Given this list of marker genes Piezo1, Bdnf, Acvr1, Dock2, Arid1a, Hacd1, Pdlim2, Sort1, Lrp2, Scgb3a1, Shh, Mir669a-8, Speg, Akap6, Ryr1, Ift20 (NCBI Gene Id 68335), Dysf (dysferlin), Smad3, Lrrc8a, Zbtb42, Popdc2, Fzd1, Slc9a1, Mfn2, Smarcb1, Gsc, Pdcd4, Scn8a, Dock1, Pdgfra, Rgs4, Id3, Pbrm1, Abcc9, Hdac2, Pitx2, Med20, Norad, Ptcd2, Gmppa, Ccl9, Myh9, Mef2a, Eid2b, Pitx1, Notch2, Cmtm5, Sostdc1, Tsc1, Cflar, Agt, Btg2, Cryab, Mapk12, Dmd, Tbx3, Chd7, Cd164, Tgfbr3, Hlx, Pdlim7, Boc, Igf2, Lemd2, Zfp418, Hdac4, Foxl2, Adgrb1, Camk1, Hira, Col11a1, Mir669a-1, Tarbp2, Ddx5, Bnip2, Trip10, Mylk3, Alx4, Hspb2, Il6, Trim63, Krt8, Cd81, Cav1, Pdlim3, Gpc1, Mettl21c, Mir145a, Tnnt2, Phf10, Adra1b, Fhod3, Adarb1, Smad6, Btbd1, Ezh2, Disp1, Dkk1, Wfikkn1, Nek5, Sirt2, Lef1, Met, Cenpf, Heyl, Actn2, Smarce1, Sema4c, Fgf10, Bmp10, Smarca2, Ephb1, Kmt5b, Scn11a, Lama2, Rbm38, G6pdx, Ehd1, Adamts5, Skil, Ark2c, Chat, AW551984, Ddx17, Cdon, Ybx3 (Y box protein 3), Akirin2 (NCBI Gene Id 67185), Pin1, Spg11, Pdlim1, Csrp3, Bin3, Nox4, Yy1, Hamp, Snw1, Mbnl1, Plekho1, Xirp2, Sgcd, Plpp7, Klk1b1, Hes1, Adm, Gsk3b, Mapk14, Sod2, Igf1, Csrp2, Vangl2, Mir675, Cacna2d2, Med1, Dmrta2, Slc8a1, Mcub, Cth, Asnsd1, Myc, Mylpf, Fgfrl1, Rxra, Nln, Nfatc2, Ccm2l, Ehd2, Notch1, Mrtfb, Sdc1, Cfd, Fzd2, Zfpm1, Ryr2, Pax3, Wnt7b, Mymk, Fgf9, Ramp2, Ereg, Pi16, Afg3l2, Pdgfrb, Lama5, Tmtc3, Mir669a-5, Mybpc3, Plg, Prok2, Dmpk, Srf, Mir669a-7, Cacybp, Myh11, Plagl1, Fkrp, Smarca4, Mnx1, Cav3 (NCBI Gene Id 12391), Smtnl1, Svil, Actl6b, Six1, Ntn3, Fktn, Prickle1 (NCBI Gene Id 68784), Cdk9, Nr4a1, Neurl2 (NCBI Gene Id 415115), Prkg1, Lama1, Megf10, Adrb1, Flt3l, Adamts15 (ADAM metallopeptidase with thrombospondin type 1 motif 15), Casq1, Alpk3, Pin1rt1, Hdac7, Hoxd9, Myo18b, Epas1, Ldb3 (NCBI Gene Id 432840), Gpx1, Mkx, Zfhx3, Foxk1, Vegfa, Fgf3, Rtl1, Sox9, Ero1a, Chuk, Fgfr2, Cxadr, Lamb2, Cav2, Dsp, Asb2, Cfh, Prkar1a, Comp, Tmod2, Bmp4, Sox11, Maml1, Ripor2, Smad4, Cited2, Fkbp1a, Xbp1, Tgfbr1, Nfatc4, Ppard, Mir214, Mymx, Dll4, Tgfb2, Klhl40, Hey1, Asf1a, Foxc1, Or10j5, Col19a1, Nkx2-5, Uqcc2, Plekhm3 (pleckstrin homology domain containing, family M, member 3), Neurog1, Wnt5b, Rbm10, Myl9, Popdc3, Nr2f2, Ctnnb1, Kdm6b, Cntfr, Kat2a, Dag1, Cntf, Mmp14, Ang2, Myom2, Hdac9, Plec, Ybx1, Ednrb, Ctdp1, Synb, Mir669a-6, Cdk1, Tmem182, Ddx39b, Cops2, Pkp2, Ep300, Wnt3a, Paxbp1, Camk2d (NCBI Gene Id 77170), Actn4, Smarcd2, Ranbp3l, Mtm1, Heg1, Dock5, Adra1a, Mstn, Bmal1, Npnt, Fhl1, Cd9, Med28 (NCBI Gene Id 66999), Actn3, Erbb3, Mbnl3, Epor, Gpcpd1, Lmod1, Myl3, Acta1, Tmem204, Naglu, Srpk3, Cxcl10, Dicer1, Ccn4, Rara, Myl6b, Actn1, Rxrb, Klhl41, Mir669a-3, Vrk3, Pias1, Mir489, Bhlhe41, Neu2, Kit, Wt1, Hdac3, Smad1, Ccl8, Negr1, Mybpc1, Vamp5, Ppara, Creb1 (NCBI Gene Id 98624), Cntnap1, Sik1 (salt inducible kinase 1), Homer1, Mir499, Rcan1, Gata6, Xirp1, Zfp689, Cxcl12, Bvht, Stac3, Chkb, Cntnap2, Vps54, Ifrd1, Gja1, Tmod1, Tshz3 (NCBI Gene Id 338507), Casq2, Myh6, Sfmbt1, Cyp26b1, Agtr2, Msc, Mamstr, Rb1, Tcf23, Casp3, Pou4f1, Map3k5, Hand1, Mef2c, Mypn, Bves, Pax7, Efemp2, Myog, Eomes, Xkr8, Foxo4, Rbpms2, Stim1, Smyd1, Etv1, Jph1, Ptbp1, Mtss1, Hivep3, Nr2c2, Rgs2, Arrb2, Pax5, Ntf3, Gper1, Wnt10b, Tbx2, Gtf3c5, Mybph, Mir669a-4 (NCBI Gene Id 100526535), Frg1, Myof, Unc45a, Rps6kb1, Flii, Igfbp5, Foxh1, Ilk (integrin linked kinase), Ankrd23, Arid5b, Nebl, Prkaa1, Ldha, Ky, Hmg20b, Des, Pdlim5, Dusp29, Hsd17b1, Tmsb4x, Il36g, Mir208a, Mylk2, Prdm6, Arid2, Map2k4, Irx3, Hopx, Il4 (interleukin 4), H3f3b, Prickle4, Myom3, Mir208b, Cxcl14, Tnf, Casp1, Ppp3cb, B4galnt2, Myt1, Dyrk1a, Lif, Nf1, Gata4, Wnt1, Flot1, Ankrd33, S100b, Tafazzin, Brd7, Akirin1, Rora, Rbm24, Tmem119, Bcl2, Mir351, Krt19, Dcaf8, Actl6a, Rbfox1, Fdps, Myocd, Mir669a-9 (NCBI Gene Id 100526491), Isl1, Kdm1a, Atp2a2, Msx1, Tcf15, Angpt1, Wfikkn2 (NCBI Gene Id 70468), Luc7l, Serp1, Fxr1, Id2, Grem1, Tcf7l2, Tnnt1, Dll1, Ccnt2, Col6a1, Tnpo2, S1pr1, P2rx2, Lncpint, Znhit1, Lmod2, Nfatc3, Mef2d, Flnc, Tanc1, Greb1l, Hinfp, C3, Unc45b, Kat5, Fbxo22, Large1, Myod1, Fbxo40, Tnni1, Utrn, Sirt1, Foxc2 (forkhead box C2), 3425401B19Rik, Actg1, Igfbp3, Vax1, Fer1l5, Hand2, Sox6 (SRY (sex determining region Y)-box 6), Zfp36l1, Tbx1, Ttn, Mir669a-10, Nfatc1, Ptgfrn, Kat8, Ankrd1, Myhas, Casp7, Maff, Fgf8, Glmn, Trim32, Myh10, Rest, Prr14, Meis1, Syna, Ppp2r3a, Ninj1, Sin3b, Mettl8 (methyltransferase 8, methylcytidine), Supt6, Cby1, Mtpn, Nol3, Myh14, Bmpr1a, Dner (NCBI Gene Id 227325), Eln, Tomm70a, Spag9, Myoz2, Tcf21, Vps13b, Usp19, Qki, Meox2, Mrtfa, Foxn2, Zmpste24, Sypl2, Gdf3, Zbed6, Hlf, Tgfb1, Dpf3, Sirt6, Rbm4, Pdlim4, Capn3, Emd, Mesp1, Notch4, Nphs1, Tll2, Cdk5, Trim72, Wnt4, Shox2, Nrap, Epo, Daxx, Smo, Zbtb18, Stra6, Crhr2, Ankrd17, Myorg, Sox4, Rpl3l, Morf4l2, Nog, Ins2, H3f3a, Csf1r, Bhlha15, Mtln, Hmgcr, Sox8, Lmna, Lamc1, Bmp2, Ppp3ca, Hamp2, Egr2, Atg7, Cacnb4, Hdgfl2, Csrp1, Tnnt3, Mylk, Lgals1, Syne1, Nmrk2, Selenon, Aplnr, Ccn3, Hspa8, Fgf6, Foxp1, Atg5, Efnb2, Egln1, Prl2c2, Xk, Frs2, Plcb1, Atp11a, Myf5, Smad7 (SMAD family member 7), Ass1, Uchl1, Ski, Cfl2, Synpo2l (synaptopodin 2-like), Nkx2-6, Cdh2, Bmpr2, Hif1an, Sox15, Smarcd1, Trip4, Ctcf, Lox, Prox1, Akt1, Psma6, Flot2 (NCBI Gene Id 14252, flotillin 2), Tnnc1, Zeb1, Il4ra, Foxp2 (NCBI Gene Id 72715), Col14a1, Ankrd2, Mybpc2, Wdr1, Hdac5, Rhoa, Eif5a, Edn1, Sra1, Eid2, Myf6, Fhl2, Pld3, T, Atf3, Adprhl1, Nid1, Avpr1a, Tbx5, Nr1d2, Akap13, Mir669a-2, Zfpm2, Calr, Capn2, Chrnd, Hoxd10, Itgb1, Myh7, Neo1, Cacna1s, Nupr1, Egr1, Smarcc2, Myoz1, Pmp22, Dtnbp1, G6pd2, Lbx1, Gm34220, Ednra, Tnni3, Fos, Dnmt1, Smyd3, Klf5, Smarcd3, Pik3r1, Chd2, Sap30, Sgcb, Eng, Dyrk1b, Tnfsf14, Lmod3, Lrp6, Coprs, Itga8, Chrna1, Tpm1, Nr3c1, Tbx18, Dubr, Btg1, Usp2, Cd53, Gdf15, Nras, Ube4b, Bcl9l, Tcap, Parp2, Lemd3, Wnt2, Slc25a4, Ppif, Lbx2, Neurl1a, Bcl9, Cripto, Hottip, Rbpj, Ddit3, Igfn1 (immunoglobulin-like and fibronectin type III domain containing 1), Flnb, Myl6, Mtor, Ly6e, Snhg15, Actc1 (actin, alpha, cardiac muscle 1), Kel, Mdm2, Tbx20, Phox2b, Hey2, Nfix, Barx2, Epc1, Rarb, Jph2, Myom1, Myl2, Mecp2, Hnrnpu, Ccnd2, Sorbs2, Nrg1, Six4, Prkd1, Foxf1, Mustn1, Tmod4, Pak1, Meg3, H1f5, Adgrb3, Ift88, Neb, Smarcc1, Gsk3a, Cavin4 (caveolae associated 4), Olfm2, Cxcl9, Adrb2, Hoxa2, Pdgfb, Tmod3, Scx, Tifab, Col3a1, Acadm, Zfp609, Ank2, Alpk2 (NCBI Gene Id 225639), Kcnj8, Pgm5, Twist1, Setd3, Kras, Fzd7, Chrnb1, Il18, Actb, Lamb1, Bin1, Ccl17, Vgll2, Lrrc10, Mir143, here is a description of the gene set: The progression of a muscle structure over time, from its formation to its mature state. Muscle structures are contractile cells, tissues or organs that are found in multicellular organisms. Mouse Gene Set: GOBP_MUSCLE_STRUCTURE_DEVELOPMENT species: Mus musculus